Given this list of marker genes Htt (NCBI Gene Id 319350), Slc7a11, Drd2, Mkks, Bcl11b, Secisbp2, Bbs1, Ogdh, Drd1, Bbs2, Hprt1, Bbs4, Aldh1a3, Lrrk2, Shank3, Foxp2, Zswim6, Mecp2, Inhba, Slitrk5, Rarb, here is a description of the gene set: studied in species Mus musculus The progression of the striatum over time from its initial formation until its mature state. The striatum is a region of the forebrain consisting of the caudate nucleus, putamen and fundus striati. Mouse Gene Set: GOBP_STRIATUM_DEVELOPMENT